The following is a description of a gene set: studied in species Mus musculus Catalysis of the removal of the 5-phosphate group of a phosphatidylinositol phosphate. Mouse Gene Set: GOMF_PHOSPHATIDYLINOSITOL_PHOSPHATE_5_PHOSPHATASE_ACTIVITY, and this is the list of marker genes: Inpp5k, Ptpmt1, Inppl1, Inpp5j, Synj1, Fig4, Inpp5b, Ocrl, Inpp5f, Inpp5d, Ptprq, Inpp5e, Synj2